The following is a description of a gene set: Mouse Gene Set: GOBP_SPHINGOMYELIN_CATABOLIC_PROCESS The chemical reactions and pathways resulting in the breakdown of sphingomyelin, N-acyl-4-sphingenyl-1-O-phosphorylcholine. species: Mus musculus, and this is the list of marker genes: Prkcd, Smpd3, Smpd5, Smpdl3b, Smpd4, Enpp7, Smpd1, Smpd2, Smpdl3a